Given this list of marker genes Cdk7, Gtf2h1, Ercc2, Psmc5, Gtf2h5, Gtf2h4, Mnat1, Ccnh, Gtf2f2, Ercc3, Gtf2h2, Gtf2h3, here is a description of the gene set: species: Mus musculus A complex that is capable of kinase activity directed towards the C-terminal Domain (CTD) of the largest subunit of RNA polymerase II and is essential for initiation at RNA polymerase II promoters in vitro. It is composed of the core TFIIH complex and the TFIIK complex. Mouse Gene Set: GOCC_TRANSCRIPTION_FACTOR_TFIIH_HOLO_COMPLEX